Given this list of marker genes ARC (activity regulated cytoskeleton associated protein), NRAS, CRKL, PCSK6, MEF2A, SRF, NGF, FRS2 (NCBI Gene Id 10818), RPS6KA5, MAPK12, TRIB1, AP2M1, TCF12, FRS3, RAC1, MAPK1, BRAF, RIT2, PIK3CA, RPS6KA1, MAP2K2, EGR2, DNAL4, MEF2C, SH3GL3, NAB2, AP2S1, RAPGEF1, NTRK2, CDK5R2, CREB1, RPS6KA2, CHD4, DNM1, RAP1A, PCSK5, DUSP3, DUSP6, VRK3, GRIN2B, MAPK11, AP2A2, NELFB, ELK1, BDNF, CLTA (clathrin light chain A), NTRK1, FOS, PPP2CB, RPS6KA3, YWHAB, ID2, SOS1, PTPRS, ASCL1, CDK5R1, STAT3, RALA, SH3GL2, RHOA, EGR1, ID3, MEF2D, AP2B1, REST, EP300, DUSP7, AP2A1, PPP2R1A, MAPKAPK3, FOSL1, EGR4, MAP2K1, IRS2, FOSB (NCBI Gene Id 2354), MAPKAPK2, PLCG1, PIK3R2, CDK5, RALB, ADCYAP1, FURIN, TPH1, KIDINS220, MAPK14, ATF2, PPP2CA, F3, TIAM1, GAB1, FYN, VGF, SHC1, CRK, ADORA2A, PPP2R5D, MAP2K5, HRAS, MAPK13 (NCBI Gene Id 5603), ID4, PIK3CB, NTF4, EGR3, GRB2, MAPK7, PTPRO, NTF3, SHC3 (NCBI Gene Id 53358), PPP2R1B, MAPK3, ATF1, ADCYAP1R1, PIK3R1, CLTC, JUND, RRAD, NAB1, SGK1, JUNB, IRS1, DNM2, BAX, LYL1 (LYL1 basic helix-loop-helix family member), KRAS, NTRK3, PTPN11, DUSP4, DOCK3, ID1, DNM3, SRC, SHC2, RALGDS, RIT1, here is a description of the gene set: species: Homo sapiens Human Gene Set: REACTOME_SIGNALING_BY_NTRKS Signaling by NTRKs